The following is a description of a gene set: Mouse Gene Set: TOX2_TARGET_GENES from publication Yevshin I, Sharipov R, Kolmykov S, Kondrakhin Y, Kolpakov F (PMID 30445619) species: Mus musculus, and this is the list of marker genes: Lims1, Zbtb37, Dhrs9, Adamts6, Fzr1, Plek, Vps26c, Wdfy2, Aars1, Rps12, Faah, Parp2, Sdf2, Gdi2, Ifrd2, Sla, Snx1 (sorting nexin 1), Zfp865, Sap30bp, Fau (NCBI Gene Id 14109), Calm2, Diaph1, Bcl9, Fdxr, Snrnp200, Prnp, Rpl18, Gpatch2l, Plekhb2, Gm27017, Rab5if, Nap1l1, Gm14221, Phf20, Fstl3, Rnf149, Tagln2, Mmaa, Rpl37, Prkrip1, Rdh1, Rpl23, Tars2, Capns1, Ptger1, Vps26a, Tab2, Mir8102 (NCBI Gene Id 102466256), Ecd, Atp8b4, Mir155hg, Qser1, Acbd6, Ptgs2os, Tmem60 (NCBI Gene Id 212090), Abt1, Zc3h13, Rps6kc1, Phlda1, Tnrc6c (NCBI Gene Id 217351), Ccr9, Birc3 (NCBI Gene Id 11796), 4930583K01Rik, Ubald2 (NCBI Gene Id 67385), Tmtc4, Cop1, Stk40, BC065397, Ern1, Trmt61b, Pafah2, Mpc2, Rngtt, Sgtb, Bcl3, Tnfsf13b, Cdkn2aip, Rab5a, Ptpn22, Tmem167b, Zfp740, St3gal2, Cipc, Tlcd1, Lratd2, Abtb1, Hdhd2, Gm15441, Gm17484 (NCBI Gene Id 100503003), Stxbp3, Ubfd1, Tubb5, Rab2b, Snora24, Ncapg2, Stk10, Eef1a1, Selenok, Rps27l, Uvssa, Gm15133, Cgas, Tet2, Gadd45g, Gm29642, Ddx42, 5430405H02Rik, Sde2, Lrrc8b, Ppp1ca, Shroom3, Cbarp, Kifc5b, Dhrs1, Rfc1, Grcc10, Dazap1, Tnip1, Abhd16a, Rbm34, Brme1, Mllt6, Wdr26, Pik3r1, Gm19280, H4c4, Cbx3, Vamp3, Trim37, Dop1b, Mmp10, Lonp2, Ptprc, Ndufa7, Btbd19, Gm14634, 1810044D09Rik, Ksr1, Tbp, Stkld1, 1700028N14Rik, Zpbp2, Eps15, Xpo1, B130034C11Rik, Fam193a (family with sequence homology 193, member A), Azin1, Fosl2, Lmbrd1, Brd2, Isy1, Atxn7l3, D230022J07Rik, Spty2d1, Gpr176, Ccn4 (cellular communication network factor 4), Gm16675, Mir5122, Jak3, Necap2, Rpl41, Gm28707, Rnps1, Mef2c, Cd2bp2, Dpysl2, Pithd1, Snhg8, Bend6, Tmub1, Arfip2, Colgalt1, Tob1, Zc3h10 (NCBI Gene Id 103284), Sik2, Tti2, Eml4, Taf4b, Zfp207, Ppm1a, Dmpk, Gm10382, Myl6b, Uba6, E230001N04Rik, Gm15558, Eif4e, Fam149b (family with sequence similarity 149, member B), Klf4, Tox4, C330018D20Rik, Hmgn2, Lmna, Samd1, Gatd1, Il23r, Paqr3, Tmed4, Ccr6, Rnf41, U2surp, Ifngr2, Prpf31, Zfp384, Fbxo3, Inip, A930012O16Rik, Rabgap1l, Zfp408, Nebl, Smg6, 1700016P03Rik, Sec31a, Mir1956, Mir484, Nop9 (NCBI Gene Id 67842), Klhl3, Polr1f, Lag3, Thumpd3, Ctcf, Pfas, Denr, Gm14250, Khk, Il3ra, Gata3, Tbrg4, Cxcr5 (NCBI Gene Id 12145), Amz2, Tinf2, Ahsa2, Phtf2, Gm16288, Lonp1, Rpl27, Klhl42, Rps28, 2310022A10Rik, Snupn, Pias4, Edf1, Puf60, Tgfb1, Eif4ebp2, Tcof1, Mgmt, Rnf44, Gm19412, Nkapd1, Ranbp2, Far1, Sh3glb1, Mrpl38, Socs2, Ctsc, Gypc, Atg2b, Atp9b, Kdm2a, Evi2, Hint3, Dck, Acvr1b, Jmjd1c, Fam168a, Bpifc, Srd5a3, Cetn4, Ntmt1, Kansl1, Prkag1, Tnfrsf4, Gins1, Gtf2b, Morc2a, Mettl4, Snhg17, Ippk, Slc36a3os, Mir8096 (microRNA 8096), Chst12, Bcl2, Sec11c (NCBI Gene Id 66286), 1700074A21Rik, Fem1b, Rasa2, Rhoa, Surf4 (surfeit gene 4), Gm23130, Otub1, Dot1l, Matcap1, Ep300, Xrn1, Hnrnpl, Mir7238, Npm3-ps1, Snapc3, Cox18, Agtpbp1, Smg1, Gm23143, Rab6a, Gltp, Ier3ip1, Tmem123, Ssbp2, Cct2, Tpm3, Gm22489, Trpm8, Dnhd1, Mrpl49, Cc2d1a, Gen1, Ptprn2, Bin3, Psmg1, Tec, Cbfb, Mir6974, Sult2b1, Sra1, Slc39a1, Cxcr6, Ppp4r1, Ccndbp1, Gatad2b, H3c6, Nip7, Slc9a1, Cnnm4, C2cd5, Ccno, Cnot4, Gm13868 (predicted gene 13868), Gle1, Fam53a, Cnksr3, Creld1, Uimc1, Tasp1, Lemd3, Zfand2a, Ibtk, Retreg1, Nras, Dnaaf9, Atxn2l, Gm10433 (NCBI Gene Id 100038378), Gm34086, Shisa5, Cish, Stra6, Btf3l4, Cdc42, Nup58, Hsf2bp, Zfp386, Zc3h4, Gstcd, Gm24016, Faf1, Sp3, Taf4, Gm15612, Mirlet7i, Pml, Adss2, Ctnna1, Rora, Pold3, Mir1945, Bach2it1, Ppp3ca, Eri1, Akt3, Gspt1, Mast4, Fbrsl1, Atp11b, Ndufs7, Gm42141, Zfp457, Gpr171, Eif3h (eukaryotic translation initiation factor 3, subunit H), Maml1, Pcgf5, Tmem229b, Ehd1, D830025C05Rik, Trbv1, Htra2, Hyou1, Cog8, Irf2 (interferon regulatory factor 2), Chd2, Dad1, Zfp62, Ifnar1, Lef1, Ywhag, Atg13, Hnrnpab, Cmtm6, Btg2, Pou2f1, Styk1, Gm16409, Oit3, Abcb8, Zranb1, Snx5, Zrsr2, Ppm1g, Marf1, Tmem30a, Alyref2, Pmm1, Cnst (NCBI Gene Id 226744), Klhdc3, Fam219a, Acot7, Cry2, Gm12743, Atp6v1h, Plekho2 (pleckstrin homology domain containing, family O member 2), Spmip2, Rhpn2, Sntb2, Usp38, Rbx1, Mir8098, Hps6, Kri1, Elmo2 (NCBI Gene Id 73997), Bsg, Plrg1, Lamtor5, Nomo1, A430093F15Rik, Ccsap, Egr2, Hbs1l, Ctla4, Ddx20, Ezr, Mea1, Gm5544, Gm11928, Gimap9, Camk2n2, Pum1, Mis18bp1, Epo, Tcf4, Tbc1d14, 1700022E09Rik, Klhl9, Letm2, Arl16 (ADP-ribosylation factor-like 16), Gm38326, Tmem170b, Tmed7, Cdc25a, Nek3, Acd, Gm22792, E2f3, Mon2, Hilpda (NCBI Gene Id 69573), Pcnp, Crabp2, Gm22226, 2310074N15Rik, Wdr89, Slc5a6, Mcfd2, H1f8, Pcif1, Ankrd13d, Scfd2, Srrm2, Prn, Shoc2, Wrap53, Gm37053, Bin2, Atp5f1d, Tmem131l, Plbd2, Anp32a, Gtf3a, Gtf3c3, Ppp1r18, Rps20, 4930429F24Rik (RIKEN cDNA 4930429F24 gene), Zfp87, Ndrg1, Dynlt4, Il2ra, Aup1, Nhlrc3, Art2b, Lrig1, Hnrnpa2b1, Tank, Actb, Hnrnph3, Wdpcp, Nrros, Papola, Med6 (mediator complex subunit 6), Tff1, Gm12711, Hivep1, Rwdd3, D730003I15Rik, Zzz3, Zyx, Rhot2, Tmx3, Cic, Cnot8, Bhlhe40, Kmt2a, Phlpp1, Nup35, Pex6, Lnpep, Tbl1xr1, Ptgr3, Arid3a, Proser1, Inpp4a, Hsd17b12, Btbd2, Slc35a1, 4632404H12Rik, Nln, Parp3, Mlec, Dhx34, Larp7, Fam124b, Snhg7os, Fnip1, Dnajc16, Zmpste24, Ncor1, Agpat5, Bard1, Cd274, Nvl, Atp5mc2, Ptpn11, Fyco1, Pxn (NCBI Gene Id 19303), Maff, Vps33b, Zfp414, Ptp4a2, Ubap2, Aamp, Rabl3, Ddhd2, Nfia, Or12j3, Lta, Med23, Elp5, Dctn4, Smad5, 1700064H15Rik, Abl2 (NCBI Gene Id 98214), Ccnd2, Ncoa1, Kat6a, Gm15663, Arid3b, Rprd1b, Prkab1, Atp6v1d, Txndc12, Rrm1, Crlf2, Mycbp2, Ago3, Eif2s1, Map3k7, Pip4k2b, Rgcc, Tfpt, Gm20753, Rangap1, Il18rap, Clic1, Secisbp2l, Tnfrsf9, Msl2, Gm12279, Mapk8, Furin, Picalm, Gtf2i (general transcription factor II I), Itga6, Mbd2, Rnf7 (ring finger protein 7), Pard6a, Srsf3, Ets1, Dnajb4, Ino80c, Prr12, Tox2, Tnik, Rtraf, Gin1, Slc25a39, Orc4, Vps37b, Gas2, Mvb12a, Pex3, A530072M11Rik, Crem, Dusp4, Usp36, Nfyb, Nos2, Mrpl17 (mitochondrial ribosomal protein L17), Esyt1, Cc2d1b, Mbd5, Erich1, Cdc26, Herpud2, Rbm25, Nxpe3, Ski, Sf3b6, Ints12, Coq8a, Mir155 (microRNA 155), Twf1, 4930577N17Rik, Gar1, Rab14, Nfkbiz, Nopchap1, 1110025M09Rik, Hspd1, Cct8, Sh2b3, Tmem43, Ccny, Rhbdd2, Ppig, Il21, Dleu2 (deleted in lymphocytic leukemia, 2), 1700030C12Rik, Pold1, Nolc1, Prpf4, Dctn5, Gm10699, Gcc1, Tcta, Trip4, Gbp5, 4933408N05Rik, Mgme1, 4933434E20Rik, Sumo3, Tbc1d10c, Gskip, Mier1, Mettl2, Kbtbd7, Mpc1, Tnfsf4, Eloa, Rapgef6, Mthfd2, Niban2, 1700104B16Rik, Gm37004, Rer1, Dnajc14, Psmc2, Idh3b, Gm27003, 4930568G15Rik, Dnajb5, Gmpr2, Cebpzos, Gtpbp8, Gnb2, Nedd8, Slc37a3, Cd82, Mybl1, Frmd6, Timm10b, Nek8, Pih1d2, Ptpn12, Fmnl3, Morn1, Adrm1, Chchd4, Nme1 (NCBI Gene Id 18102), Frmd8os, Arhgef1, Psmc6 (proteasome (prosome, macropain) 26S subunit, ATPase, 6), Gm22322, Ino80b, D330041H03Rik, Tnfsf14, Prss46, Zfp91, Gtf3c6, Eprs1, Skil, Gbp3, 4931422A03Rik, Plagl2, Baiap2, Sp3os, 3300005D01Rik, Dusp19, Mir3100, Sfr1, Dkc1 (NCBI Gene Id 56842), Or10aa1, Tfrc, Gzmb, Rev3l, Scaf1, Zfp330, Ptgs2, 1810024B03Rik, Pbld2 (NCBI Gene Id 67307), Cxxc1, Laptm5, Snord118, Mfap1b, Smc6, Csnk1a1, Rcor1, Nucks1 (nuclear casein kinase and cyclin-dependent kinase substrate 1), Grap, Dctn2, S100pbp, Morf4l2, Nfkb1, Mindy1, Tufm, 5730420D15Rik, Tdp1, Cltc, Dcaf6, Pvt1, Gm20109, Mir212, Slc25a45, Ctnnb1, Bcl7c, Arap1, Lars2, Map3k14, St6galnac6, Gm16794, Vkorc1l1, Stau1, Rrp9, Gpr132, Yars1, Ctdnep1 (CTD nuclear envelope phosphatase 1), Bax, Klf13, Mief1, Atad2, Rpph1, Abhd4, Rab18, H1f3, Prdx6, Atraid, Ankrd10, Slc16a6, Ppp1r15b, Atg7, Rimoc1, Vamp1, Slc7a1, Susd6, Ssr1, C2cd3, Fam241a, Otud6b, Nabp2, Mogat1, Rad21, 5430435K18Rik, Plgrkt, Hexim2, Akirin1 (NCBI Gene Id 68050), Fas, Slc9b2, Dnajc2, Gtf2e2, 2700099C18Rik, Gm26224, Unc13a, Dnai4, Eif3e, Eif1a, Rhog, Gstp3, Rps15a-ps5, Btla, Ube2d2a, Cetn3, Tug1, Gm10463, Gpr155, Rhoq, Zgrf1, Ubb, Mapk1, Lrrc8a, Sphk2, Polr2m, Gatad2a, Stx11, Sptlc1, Usp28, Ezh1, Pip5k1c, Arhgap21, Itgal, Usp9x, Gm25794, Tti1, Adap1, Pla2g6, Ubap2l, Mzt2, Cops6, Hif1a, Ripk2, Inpp1, Pcbp4, Gabpb1, Ube2q1, Nup107 (nucleoporin 107), Ppp1cc, Tnfrsf8, 2310010J17Rik, Nhp2, Dnajc13, Gm11767, Taok3, Magohb, Fam76a, Crebzf, Lman2, Sod2, Ctdsp2, Atp2c1, Shld1, Oga, Phax, Garin3, Trmt12, Farp1, Nelfe, Zbtb18 (zinc finger and BTB domain containing 18), Tex30, Dnai1, Gm17435, Nck1, Map2k6, Rasa1, Rasal3, Evi2a, Bod1l, Rnf216, Dnajb2, Eif4a1, Cdk13, Xpo6, Taco1, Snd1, Ubc (ubiquitin C), Slfn10-ps, Slc15a3, Gm4890, Ccdc47, Snora21, Mt1 (NCBI Gene Id 17748), E130307A14Rik, Tiam1, Mtmr4, Txnip, Slc35e1, Lat, Ggnbp2, Nup93, Hgs, Dnaja2, Rrad (Ras-related associated with diabetes), Tbc1d7, Acot2, A730017L22Rik, Sec23a, Tm9sf3, Pramel12, Rps7, Snora17, Klhl35, Atrn, 4930532G15Rik, Pnrc1, Irf2bpl, E330034L11Rik, Aurka, Rmnd5a, Dhx40, Recql5, Cap1, Med14, Ncbp3, Alg8, Tmod1, Gm8818, Set, Gm12920, Susd3, Gimap7, Cxcl10, 4921531C22Rik, Nfe2 (nuclear factor, erythroid derived 2), Mcrs1, Wdr5, Kbtbd2 (NCBI Gene Id 210973), Plec, Hspe1, Ogg1, Mir142hg, Rprd1a, Bbip1, Kcnn4, Trp53, Enthd1, Paxx, 5730455P16Rik (NCBI Gene Id 70591), Nudt9, Tnfaip3, Nav2, Trim59, Srr, Phf19, Nabp1, Commd9, Gas5, Il2rb, Map9, Skic2, Stx4a, Bmi1, Mbnl1, Spag9, Mob4, Atosb, Mex3b, Serf2, Gm18830, Arhgap1, Gm9903, Hjurp, Sfxn5, Tfb2m (NCBI Gene Id 269153), Anp32b, Tcf3, Ptpn5, Peli1, Etv6, Vcan, Palb2, Fbxw7, Zscan25, Larp4b, Harbi1, Gm2093, Tmem220, Itprid2, Nmt2, Fam221a, Ears2, Bcl6 (NCBI Gene Id 12053), Gm26169, Arhgap15 (NCBI Gene Id 76117), Leprot, Vmp1, Gtf2e1, Ano7, Ly6a, Tram2, Neat1, Wasl, Snord13, Pik3r3, Ift46 (intraflagellar transport 46), Pnkd, Aldh7a1